Given this list of marker genes RAB11FIP3, POLDIP2, AURKB, NUP62, INCENP, RAB11A, WNK1, KIF20B, EXOC7, CDCA8, ECT2, BIRC5, ARF6, here is a description of the gene set: Human Gene Set: GOBP_POSITIVE_REGULATION_OF_MITOTIC_CYTOKINESIS species: Homo sapiens Any process that activates or increases the frequency, rate or extent of mitotic cytokinesis.